The following is a description of a gene set: species: Mus musculus electronically inferred by orthology from the curated human pathway This event has been computationally inferred from an event that has been demonstrated in another species.<p>The inference is based on the homology mapping from PANTHER. Briefly, reactions for which all involved PhysicalEntities (in input, output and catalyst) have a mapped orthologue/paralogue (for complexes at least 75% of components must have a mapping) are inferred to the other species. Reactome Pathway: AMPK inhibits chREBP transcriptional activation activity part of: Integration of energy metabolism, and this is the list of marker genes: Adipoq, Adipor1, Adipor2